Given this list of marker genes ZBTB12, DUSP4, GRB14, TUBA4A, MFAP4 (microfibril associated protein 4), MEOX1, RND3, TBL2, JUNB, DNAJC5G, NNAT, KCTD15, PHLDA1, TAC1, EGR1, GREM2, UTP6, LHFPL4, SLC22A6, DDB1, KRT84 (NCBI Gene Id 3890), here is a description of the gene set: species: Mus musculus The tuberous sclerosis complex (TSC) proteins TSC1 and TSC2 regulate protein translation by inhibiting the serine/threonine kinase mTORC1 (for mammalian target of rapamycin complex 1). However, how TSC1 and TSC2 control overall protein synthesis and the translation of specific mRNAs in response to different mitogenic and nutritional stimuli is largely unknown. We show here that serum withdrawal inhibits mTORC1 signaling, causes disassembly of translation initiation complexes, and causes mRNA redistribution from polysomes to subpolysomes in wild-type mouse embryo fibroblasts (MEFs). In contrast, these responses are defective in Tsc1(-/-) or Tsc2(-/-) MEFs. Microarray analysis of polysome- and subpolysome-associated mRNAs uncovered specific mRNAs that are translationally regulated by serum, 90% of which are TSC1 and TSC2 dependent. Surprisingly, the mTORC1 inhibitor, rapamycin, abolished mTORC1 activity but only affected approximately 40% of the serum-regulated mRNAs. Serum-dependent signaling through mTORC1 and polysome redistribution of global and individual mRNAs were restored upon re-expression of TSC1 and TSC2. Serum-responsive mRNAs that are sensitive to inhibition by rapamycin are highly enriched for terminal oligopyrimidine and for very short 5' and 3' untranslated regions. These data demonstrate that the TSC1/TSC2 complex regulates protein translation through mainly mTORC1-dependent mechanisms and implicates a discrete profile of deregulated mRNA translation in tuberous sclerosis pathology. Genes translationally up-regulated by serum in MEF cells (embryonic fibroblast) lacking TSC1. Human Gene Set: BILANGES_SERUM_SENSITIVE_VIA_TSC1 from publication Bilanges B, Argonza-Barrett R, Kolesnichenko M, Skinner C, Nair M, Chen M, Stokoe D (PMID 17562867)